The following is a description of a gene set: Genes up-regulated in macrophages stimulated by IFNG for 3h: control versus primed by IFNG. from publication Hu X, Park-Min KH, Ho HH, Ivashkiv LB (PMID 16148108) Human Gene Set: GSE1925_CTRL_VS_IFNG_PRIMED_MACROPHAGE_3H_IFNG_STIM_UP IFN-gamma transcriptional responses in control and IFN-gamma primed primary human macrophages species: Homo sapiens, and this is the list of marker genes: UBE3B, RPS5, RPS3, SFT2D2, CTPS1, AIFM1, TCP1, FBL, ETNK1, TMX3, INTS3, RPS26, NACAD, SCAPER, RPL12, NUP205, TTLL4, GDNF, OTUD6B, PHF12, ANKFN1, MINK1, MRPS9, WDR37, RGS10, MTIF2 (NCBI Gene Id 4528), HAUS1, EZH2, CRCP, RPL36, SELL, ACAA2, ATP5PB, CSF2, GTF2E2, IKBKE, INPP5B, PSMD11, CPXM1, RAD17, AGA, HAX1, COQ2, CNOT6, RAD18, INPP1, GSTA3, NACA, PRKCI, EXOSC1, USPL1, PCF11, TRAF5, MRPL22, RPL22, EDAR, NR2C2, AKAP10, UBTF, SLAMF6, ERLIN2, NUBP1, PTPRE, HIPK1, PUS3 (pseudouridine synthase 3), RAPGEF6, SULT1A1, PRKAA1, ZNHIT6, KDM7A, TNFSF8, PRAMEF8, CLIP1, HIPK2, URI1, INO80, DNAJC3, MSI2, RPL30, SOS2, RTP2, CD80, ENO3, SNTB2, STAT1, RBMX, PCMTD2, CCT4, PIGP, PDS5B, RIGI, RNF122, MRPL36, CCT6A, ZBTB37, AZIN1 (NCBI Gene Id 51582), MFSD6, GAN, LTA4H, SLC7A6OS, USP24, MADD, DDHD1, DKC1, HERC2 (HECT and RLD domain containing E3 ubiquitin protein ligase 2), STT3B, LETMD1, TRIM39, IRAK4, RUVBL1, MIR409, RUFY2, MRPS17, CAMTA1, VWA5A, POLI, MPHOSPH10, TLR1, DMXL1 (NCBI Gene Id 1657), FIZ1, WRAP53, CASP1, TRAF1, HSD17B10, GLTP, MYH9, GFUS, CNOT6L, RAD23B, EIF3M, TUBD1, CTSS, UBC, COQ8A, RPL3, PTP4A1, UTRN, ATAD2B (NCBI Gene Id 54454), HEATR1, HUWE1 (NCBI Gene Id 54789), MRPL2, RPS2, FBXL20, GCC2, SIGMAR1, PPP6R3, RRAGB, ZBTB42, CCNL1, SIN3B (SIN3 transcription regulator family member B), IFIT1, CBLB, SIDT1, SARAF, TOMM20, RPLP0, ATP5MC1, PARP8, XPO7, COL4A4, RACK1, NFX1, UTP20, TCF7, GAS5, TRAPPC5, CAB39L, CEP95, PARP14, PTTG1, KDM6A, SLC35B4, ZPBP2, GRIPAP1